The following is a description of a gene set: Mouse Gene Set: MIR_5624_5P Genes predicted to be targets of miRBase v22 microRNA mmu_miR_5624_5p in miRDB v6.0 with MirTarget v4 prediction scores > 80 (high confidence targets). from publication Chen Y, Wang X (PMID 31504780) studied in species Mus musculus, and this is the list of marker genes: Qng1, Prrg1, Igsf10, Tasor, Crebrf, Tcf12, Exo5 (exonuclease 5), Tdg, Snai2, Cat, Mrps36 (mitochondrial ribosomal protein S36), Csmd1, Mlx, Psd3, Ckmt2, Fabp7, Gng10, Jakmip2, Ehbp1, Ncaph2, Fam199x, Hapln1, Thrb, Mecp2, Dcun1d1, Tmem106b (NCBI Gene Id 76086), Klf10, Naaladl2, Got2, Heph, Rnf111, Erg, Epb41l3, Psmg2, Gpn3, BC016579, Snn (NCBI Gene Id 66305), Ddit4l, Brinp3, Cpne2, Gins2, Rgs17, Sall1, Rapgef2, Fubp1, Pacrg (PARK2 co-regulated), Acap2, Klhdc2, Glcci1, Hipk3, Sox9, Pfkl, Ryr2, Tfap4, Nfia, Plrg1, Clpx, Zbtb44, Rgn, Ube2e3, Tnfaip8l3, Fam149a, Arnt2, Col5a1, Yap1 (NCBI Gene Id 22601), Atp6v1d, Nebl, Prkar2b, Vwa5a, Zfp808, Mup21, Vkorc1l1, Sema6a, Atad1, Picalm, Dock4, Tm9sf1, Rimklb, Ammecr1, Ppm1b, Usp29, Snrpb2, Gpr137b, Hoxa1, Alyref2, E4f1, Rbbp6, Cysltr1 (cysteinyl leukotriene receptor 1), Il17a, Mical1, Adam19, Rab3c, Pi4k2b, Mtbp, Zfp330, Ubac2, Rabl2, Taok3, Sgcb, Serpine3, Serpini1, Nefl, Bmp5 (bone morphogenetic protein 5), Ptbp3, Slc18a2, Tipin (NCBI Gene Id 74321), Bicd1, Rab8b, Mrpl1, Colec12, Stat5b, Syngr3, Rgs1 (NCBI Gene Id 50778), Cnr1, Zfp706, Il1rn, Samd8, Zfp654, Dnal4, Naa10, Spink14, Atp6v1c2, Eya4, Trp53 (NCBI Gene Id 22059), Dyrk4, Fam50a (NCBI Gene Id 27560), Pof1b, Kcnj16, Atxn1, Zfp608, Fbxl17, Pparg, Phc3, Efhd1, Cldn4, Cyth3, Fbxo42, Cdk6, Samd5, Sec14l1, Mindy2, Hspbap1, Sgce, Kmt2c, Rfesd (NCBI Gene Id 218341), Hgf, Foxj1, C9orf72, Peg3, Ide, Atp5f1c, Dennd5b, Tmem258, Atp5mk, Usp14, Cpeb3, Cadm2, Ubqln1, Ugt3a2, Satb2, Fxr1, Fmr1, Kcnk5, Lrrc7, Fdx1, Galnt7, Cd40, Id1, Kif3b, Gm8369, Cdk7, Wdr44, Mn1 (NCBI Gene Id 634779), Nbr1, Lurap1l, Tmem236, Mpdz, Becn1, Qki, Ostm1, Rnf145, Rac3, Pcnp, Psmb8